Given this list of marker genes Fgf23, Fgf10, Fgf20, Fgf2, Fgf7, Fgf16, Grb2, Fgf22 (NCBI Gene Id 67112), Fgf1, Fgf5, Hras, Fgf8, Fgf17, Fgf4, Shc1, Fgf6, here is a description of the gene set: species: Mus musculus electronically inferred by orthology from the curated human pathway part of: Downstream signaling of activated FGFR2 This event has been computationally inferred from an event that has been demonstrated in another species.<p>The inference is based on the homology mapping from PANTHER. Briefly, reactions for which all involved PhysicalEntities (in input, output and catalyst) have a mapped orthologue/paralogue (for complexes at least 75% of components must have a mapping) are inferred to the other species. Reactome Pathway: SHC-mediated cascade:FGFR2